Given this list of marker genes MTOR, PLEK2, CARMIL2, GSK3B, P2RX7, MIEN1, EPS8L3, CENPJ, EPS8, CDC42EP4, RP1, FSCN1, ATMIN, BRK1, NCKAP1, CDC42EP5, OCLN, PLCE1, ABI2, CYFIP1, RALA, SRF, PLEKHM1, MYO3A, PPP1R35, NRP1 (NCBI Gene Id 8829), WNT1, RHOQ, TENM2, CLRN1, TTBK2 (NCBI Gene Id 26044), RAC2, FMR1, MNS1, AGRN, RAC1, CDC42EP2, RIPOR2, BBS4, CDC42EP3, KIT, TGFB3, CDC42EP1, CFL1, C15orf62, HTT, MYO3B, EPS8L2, GPM6A, HAP1 (NCBI Gene Id 9001), F2RL1, CCL19, FNBP1L, COBL (cordon-bleu WH2 repeat protein), PIK3CA (phosphatidylinositol-4,5-bisphosphate 3-kinase catalytic subunit alpha), IFT88, WRAP73, WASL, RAB11FIP3, WASHC1, DEF8, ZMYND10, PFN1, AKIRIN1, FAM98A, CCDC88A, ZMYND8, TWF2, KCTD17, EPS8L1, IFT20, CEP135, DOCK11, TENM1, MSTN, SAXO1 (NCBI Gene Id 158297), ENTR1, TGFBR1, CCR7, CDC42, AVIL, ARAP1, NDEL1, FRMD7, WASF2, APC (NCBI Gene Id 324), TAPT1, PLPPR5 (phospholipid phosphatase related 5), DZIP1, SEPTIN9, AUTS2, FUZ, ARHGAP35, PALM, HRAS, PIK3R1, SEPTIN7, ACTR2, DPYSL3, CCL21 (NCBI Gene Id 6366), ACTR3, NEURL1, CCP110, MARK4, NLGN1, CEP120, CROCC, HSP90AA1, ANLN, ARPC2, P2RY12, here is a description of the gene set: species: Homo sapiens Human Gene Set: GOBP_POSITIVE_REGULATION_OF_PLASMA_MEMBRANE_BOUNDED_CELL_PROJECTION_ASSEMBLY Any process that activates or increases the frequency, rate or extent of plasma membrane bounded cell projection assembly.